Given this list of marker genes PARK7, PRDX6, PRDX4, PRDX1, PRDX5, PRDX2, SELENOF, PRDX3, here is a description of the gene set: Human Gene Set: GOMF_PEROXIREDOXIN_ACTIVITY Catalysis of the reaction:-dithol + ROOH =-disulfide + H2O + ROH. species: Homo sapiens